The following is a description of a gene set: studied in species Mus musculus Binding to hydroxyapatite, the calcium phosphate mineral of formula Ca10(PO4)6(OH)2 found both in rocks of nonorganic origin and as a component of bone and dentin. Mouse Gene Set: GOMF_HYDROXYAPATITE_BINDING, and this is the list of marker genes: BC037156, Bglap, Bglap2, 5530400C23Rik, Muc19, Amelx, Bglap3, Hacd1, Apoe